Given this list of marker genes SEMA6A, BDKRB1, LTB, RASGRP3, LFNG, RGS16, MYB, GAS2, SCG2, ATF3, MTSS1, ITGA1, SYTL2, IGFBP5, TAMALIN, CCR6, RAB37, BDKRB2, RASA4, RNF128, IGFBP1, ANGPT2, ADGRG1, KRT14, SMYD3, PPP1R16B, KRT13, RHOBTB3, SCG3, VDR, JAG2, SSTR1, CLDN14, RAB3B, CHGB, CBFA2T3, RASSF4, BMF, KLK1, SSTR2, EDN3, RET, SEMA3E, CALY, KLK3, DLL1, here is a description of the gene set: from publication Osada H, Tomida S, Yatabe Y, Tatematsu Y, Takeuchi T, Murakami H, Kondo Y, Sekido Y, Takahashi T (PMID 18339843) Human Gene Set: OSADA_ASCL1_TARGETS_UP studied in species Homo sapiens The proneural basic-helix-loop-helix protein achaete-scute homologue 1 (ASH1) is expressed in a very limited spectrum of normal and cancerous cells in a lineage-specific manner, including normal pulmonary neuroendocrine cells and lung cancer cells with neuroendocrine features. Our previous results indicated that ASH1 may play a crucial role in the growth and survival of lung cancers with neuroendocrine features, which prompted us to investigate the molecular function of ASH1 in relation to its involvement in carcinogenic processes. Herein, we report for the first time that ASH1 functions as a dual transcription factor by activating neuroendocrine differentiation markers and also repressing putative tumor suppressors. This protein was found to inactivate DKK1 and DKK3, negative regulators of Wnt/beta-catenin signaling, E-cadherin, and integrin beta1 through ASH1-mediated deacetylation and repressive trimethylation of lysine 27 (H3K27me3) of histone H3 in the promoter regions of DKK1 and E-cadherin. In addition, ASH1-transduced A549 adenocarcinoma cells exhibited markedly altered morphology characteristics compared with lung cancer cells with neuroendocrine features both in vitro and in vivo and also grew faster in vivo. Our results provide important clues for a better understanding of the molecular and cellular biological roles of ASH1 in the process of carcinogenesis of lung cancers with neuroendocrine features and warrant future investigations to shed light on the lineage-specific dependency of this transcription factor with dual functions. Genes up-regulated in A549 cells (lung cancer) upon expression of ASCL1 off a viral vector.